Given this list of marker genes Pik3c3, Svip, Rab3gap2, Rab3gap1, Gba1, here is a description of the gene set: species: Mus musculus Any process that activates or increases the frequency, rate or extent of protein lipidation. Mouse Gene Set: GOBP_POSITIVE_REGULATION_OF_PROTEIN_LIPIDATION